The following is a description of a gene set: studied in species Mus musculus Mouse Gene Set: GOBP_POSITIVE_REGULATION_OF_TRIGLYCERIDE_BIOSYNTHETIC_PROCESS Any process that increases the rate, frequency, or extent of triglyceride biosynthesis. Triglyceride biosynthesis is the collection of chemical reactions and pathways resulting in the formation of triglyceride, any triester of glycerol., and this is the list of marker genes: Kat5, Ldlr (NCBI Gene Id 16835), Ctdnep1, Tcf7l2, Plin5, Gpam, Rgn, Apoc3, Nr1h2, Gpld1, Slc27a1, Srebf1, Mfsd2a, Cnep1r1, Dgat2, Dgat1, Acsl5, Nr1h3, Scarb1